Given this list of marker genes MAP2K1, SOS1, GRB2, MAPK3, SOS2, SRC, ELK1, NRAS, ARAF, KRAS, HRAS, RAF1, MAP2K2, MAPK1, BRAF, here is a description of the gene set: Pathway Definition from KEGG: X -> SRC -> GRB2 -> SOS -> RAS -> RAF -> MEK -> ERK -> ELK1 Human Gene Set: KEGG_MEDICUS_PATHOGEN_HBV_HBX_TO_RAS_ERK_SIGNALING_PATHWAY HBV HBx to RAS-ERK signaling pathway. Pathway ID: N00540. Pathway type: Pathogen. Pathway class: nt06263 Hepatocellular carcinoma. species: Homo sapiens